The following is a description of a gene set: Pathway Definition from KEGG: (GSK3B+APC) // AXIN* // CTNNB1 -> TCF/LEF => (MYC,CCND1) Mutation-inactivated AXIN to Wnt signaling pathway. Pathway ID: N00242. Pathway type: Variant. Pathway class: nt06263 Hepatocellular carcinoma. studied in species Homo sapiens Human Gene Set: KEGG_MEDICUS_VARIANT_MUTATION_INACTIVATED_AXIN_TO_WNT_SIGNALING_PATHWAY, and this is the list of marker genes: TCF7L1, AXIN1, CCND1, CTNNB1, TCF7, LEF1, APC, GSK3B, MYC, TCF7L2